The following is a description of a gene set: from publication Yevshin I, Sharipov R, Kolmykov S, Kondrakhin Y, Kolpakov F (PMID 30445619) Human Gene Set: PITX1_TARGET_GENES studied in species Homo sapiens Genes containing one or more binding sites for (PITX1) in their promoter regions (TSS -1000,+100 bp) as identified by GTRD version 20.06 ChIP-seq harmonization., and this is the list of marker genes: ZNF3, PPWD1, MLEC, TMEM59, IL17RA, OXSR1, TDG, BAZ1B, NCAPD2, PCDH1, ATAD1, ALG3, UBFD1, DARS2, COMMD1, CFAP298, MFAP3, SERTAD3, SDHA, MCEE, PPRC1, SLC30A5 (NCBI Gene Id 79021), COX15, CLIC1, TMEM62, PPM1D, MGAT1, ZNF740, TFAM, UQCRC2 (ubiquinol-cytochrome c reductase core protein 2), HERC1, AK3, MMAB, MED18, PCCB, DMXL1-DT, CYP51A1, ZBTB17, RHEB, FIS1, SNX17, RBM12B, EEF1A1, CCT3, ADGRF3, CROCCP2, GAPDH (glyceraldehyde-3-phosphate dehydrogenase), FBL, LSM1, PSMD12, ITFG2-AS1, SLC38A1, GAU1, PPIP5K2, CENPK (centromere protein K), SAMM50, AMN, ARMH4, COX19, NT5C3A, PPP4R3B, RBM7, PRMT2, EIF2B4, RPL39P40, ATG9A, PRMT5-AS1, SHARPIN, IPO11, HIGD2A, ACADSB, SPRTN (NCBI Gene Id 83932), FAR1-IT1, UIMC1, ZNF669, PTBP1 (NCBI Gene Id 63477), GRPEL2, GUK1, SLC52A3, SPAG7, AHCYL1, PPIL2, LSR, SCYL3, TCEANC2, CUTC, SYNCRIP, KIAA1549, FADS1, FAM174B, ZMYND12, SLC35A4, TMEM42, BOD1L1, RABIF, PSMA3-AS1, VAMP1, RPLP0, ELP6, FBXL18, TULP3, AGPAT1, HNRNPA1, SRGAP3, MEPCE, TBC1D19, TTC32, CADM4, DTL, STOML1, ANKRD13C-DT, FNIP1, SNORD101, SMG9, CDC7, FAM114A2, AGBL5-AS1, RAB4B-EGLN2, CCNB1, TRIM26, SERP1, BLOC1S5-TXNDC5, VPS18, PSMD9, RABGEF1, ABHD2, LZIC (leucine zipper and CTNNBIP1 domain containing), GUSB, RN7SL521P, IFNAR1, COQ10B, CRB3, SPATS2L, RCCD1, TMEM143, CSNK2A1, MMUT, SPEF2, CEP85 (NCBI Gene Id 64793), NUP42, RAB11A, GON7, NOL7, MRPL51, EWSAT1, LEO1, ALDOA, RPS12, ENSG00000254718, PARP3, AGBL5, ESRP2, MRM3, RBM12B-DT, BNIP1, FBXO38, MFSD11, RNA5SP473, CCDC121, ANKFY1, CCDC97, ZCWPW1, SELENOI, MAPK14, APPBP2-DT, TMEM14C, KATNBL1, ARID4A, MPND, TMEM19, FBXL13, HMGXB3, RNU5A-1, ERBB3, SNAI3-AS1, UBR7, IPPK, IKZF5, CD27-AS1, GTF2IRD1P1, TTC32-DT, NAA80, GIN1, DDX46, SMIM2-AS1, LINC00933, DNAJB12, MRPL55, PA2G4, EARS2, ENC1, DLEU2, ATP7B, ANKZF1 (NCBI Gene Id 55139), IQCH, MVD, XRCC6, C20orf96, PPCS, DLEU1, SLC38A10, MAN2C1, RPS17, G3BP1, FSIP1, DUSP19, ALG11, EXOC8, ASH2L, CENPL, LMO7, IK, MSH5, NR1H2, CENPQ, UBE2Q2P1, CCDC163, MIR375, MPHOSPH10, LYRM7, THBS4, FRMD5, FEM1B, MLF2, ARMC10, CAPS2, RAB10, BUD13-DT, ENSG00000224090, UBTD2, DDX55, NDUFA2, FAR1, ECE2, RNU6-1, GLOD4, TAPBPL, DIMT1 (NCBI Gene Id 27292), BRAP, ACKR2, CCDC127, ZRANB3, KLHDC10, CBX5 (chromobox 5), STAP2, UBLCP1, PIP5K1B, SLC35E3, OCIAD1, DHODH, EIF2S1, PPM1A, ENSG00000275765, RNU6-681P, PPTC7, BLOC1S5, ADPGK, TUBD1, LINC02427, RAB4B, SYNGR4, SLC25A12, MBD1, DMAC2, VCPIP1, H2BC7, NOP16, SREK1, MAK16, SNRPA1-DT, PPP1R12A, ITFG2, BUD13, NAA25, RPS6KB1, MAF1, H2AZ2-DT, YEATS4, MIR5091, SEPHS2, AAGAB, GAPDH-DT, ZNF497, SNRPA1 (small nuclear ribonucleoprotein polypeptide A'), SRSF2, ATP6V1D, SELENOT, CFAP298-TCP10L, PCSK9, FBXO38-DT, SLC11A2, AMN1, ARAP1, EMC4, KDM4A, DESI1, BRK1, EFHC1, RRP9, RUSC1, TTC1, MST1P2, ABHD11, TSACC, BRAF, ZNF184, SLC25A45 (solute carrier family 25 member 45), GCDH, MANBA, ANKRD13C, PTMA, MTHFD1, GNAI2, ARL6IP1, PXN-AS1, NMNAT1, PRMT1 (protein arginine methyltransferase 1), MAP2K3, UQCC6, STARD10, CRYZL1, EIF1, ORC2, VSIG10, PML, CMSS1, ACTR2, ZNF398, FBXO22, THUMPD3, WDR89, SPTY2D1, APBB3, PGGT1B, HYAL3, MVK, GPRC5A, ICAM3, LNPEP, ITSN1, DMXL1, APPBP2, RNF34, INTS7, SLC22A18, RFC2, ANAPC5, R3HDM1 (R3H domain containing 1), GPN1, C5orf24